Given this list of marker genes CTSD, TNFRSF21, FOXP3, SNRK, SLC25A23, CPAMD8, TSR1 (TSR1 ribosome maturation factor), TRARG1, NAT10, SRF, PARM1, KLHL31, RELN, P2RY2, VIT, KIF13A, ZNF135, ZFHX3, SLC25A22, BMP4, MS4A2, ZNF580, KLHL4, KBTBD3, MEF2A (NCBI Gene Id 4205), PDZD2, TMEM151B, FOXI2 (forkhead box I2), U2AF2 (U2 small nuclear RNA auxiliary factor 2), BLOC1S5, LASP1, FAM131B, C3orf70, CHD3, GCN1, DLG4, VDAC3, PUM2, EEF2K, PSMD3, ELAVL3, GFOD1, CD177, SCAPER, DHDDS, CCDC120, PKLR, NOL4L, KLF7, KRTAP5-11 (keratin associated protein 5-11), CCDC91, CACNA1A, GRIP2, ANAPC7, PPFIA1, PCNX1, CREBBP, SHISA2, COLGALT1, ELAVL1, COX20, CCDC97 (coiled-coil domain containing 97), CHD2, DCAF8, CACNG2, NR3C1, GNAT1, EMP2, GRID1, CYP2S1, ZEB2, MCM3, SLC25A45, CADM1, RSPO4, MPIG6B (NCBI Gene Id 80739), PARP15, CTBP1, SPNS2 (SPNS lysolipid transporter 2, sphingosine-1-phosphate), CCR7, here is a description of the gene set: Human Gene Set: MIR10401_5P Genes predicted to be targets of miRBase v22 microRNA hsa-miR-10401-5p in miRDB v6.0 with MirTarget v4 prediction scores > 80 (high confidence targets). from publication Chen Y, Wang X (PMID 31504780) species: Homo sapiens